The following is a description of a gene set: species: Homo sapiens Human Gene Set: GOBP_REGULATION_OF_TRANSMISSION_OF_NERVE_IMPULSE Any process that modulates the frequency, rate or extent of transmission of a nerve impulse, the sequential electrochemical polarization and depolarization that travels across the membrane of a neuron in response to stimulation., and this is the list of marker genes: CHRNB4, CARTPT, ITGA2, TYMP, FGF12, FMR1, GLRA1 (glycine receptor alpha 1), HCRT, GHSR, AVPR1A, TNR, GBA1 (NCBI Gene Id 82008), GHRL, TRPA1, MTNR1B, AVP (arginine vasopressin)